Given this list of marker genes Crh, Mdk, Armc5, Wnt4, Nr5a1, Pdgfra, Insm1, Igf1r, Smad2, Dkk3, Pbx1, Hmga2, Crhr1, Arid5b (NCBI Gene Id 71371), Cited2, Stra6, Ly6e, Nf1 (NCBI Gene Id 320618), Wt1, Wnt11, Smad3, Nr3c1, Apoa1, Insr, Smad4, Nr0b1, Cyp1b1, Cdkn1c (NCBI Gene Id 12577), Pdgfrb, Tspo, Ascl1, here is a description of the gene set: studied in species Mus musculus The process whose specific outcome is the progression of the adrenal gland over time, from its formation to the mature structure. This gland can either be a discrete structure located bilaterally above each kidney, or a cluster of cells in the head kidney that perform the functions of the adrenal gland. In either case, this organ consists of two cells types, aminergic chromaffin cells and steroidogenic cortical cells. Mouse Gene Set: GOBP_ADRENAL_GLAND_DEVELOPMENT